The following is a description of a gene set: Metaplastic carcinoma of the breast (MCB) is a poorly understood subtype of breast cancer. It is generally characterized by the coexistence of ductal carcinomatous and transdifferentiated sarcomatous components, but the underlying molecular alterations, possibly related to epithelial-mesenchymal transition (EMT), remain elusive. We performed transcriptional profiling using half-a-genome oligonucleotide microarrays to elucidate genetic profiles of MCBs and their differences to those of ductal carcinoma of breasts (DCBs) using discarded specimens of four MCBs and 34 DCBs. Unsupervised clustering disclosed distinctive expression profiles between MCBs and DCBs. Supervised analysis identified gene signatures discriminating MCBs from DCBs and between MCB subclasses. Notably, many of the discriminator genes were associated with downregulation of epithelial phenotypes and with synthesis, remodeling and adhesion of extracellular matrix, with some of them have known or inferred roles related to EMT. Importantly, several of the discriminator genes were upregulated in a mutant Snail-transfected MCF7 cell known to exhibit features of EMT, thereby indicating a crucial role for EMT in the pathogenesis of MCBs. Finally, the identification of SPARC and vimentin as poor prognostic factors reinforced the role of EMT in cancer progression. These data advance our understanding of MCB and offer clues to the molecular alterations underlying EMT. studied in species Homo sapiens from publication Lien HC, Hsiao YH, Lin YS, Yao YT, Juan HF, Kuo WH, Hung MC, Chang KJ, Hsieh FJ (PMID 17603561) Human Gene Set: LIEN_BREAST_CARCINOMA_METAPLASTIC_VS_DUCTAL_DN Genes down-regulated between two breast carcinoma subtypes: metaplastic (MCB) and ductal (DCB)., and this is the list of marker genes: PLEKHA6, TSTD1, DACH1, ZNF552, ERBB2, ZG16B, IFI44L, AZGP1, PRR5-ARHGAP8, LAMP5, FBXL16 (F-box and leucine rich repeat protein 16), MANEAL, TPD52, AR, DYNLRB2, REEP5, VAV3, SERTAD4, PLAAT3, SCGB1D2, SCGB2A2, MYO5C, TFF3, CREB3L4, TOM1L1, KRT19, EPN3, NHERF1, TMEM125, INPP5J, STK16, EPPK1, COX6C, NAT1, KRT18P64, MMEL1, LRRC17, MUCL1, HCAR1, ABAT, TESMIN, ITGAD, FSIP1, FXYD3, PIP, ADIRF, TMEM25, ZDHHC11, CCDC125, AGR2, SPDEF, ARSD, EPCAM, BIK, FRZB, MB, ACOT4, RTN4RL1, TBC1D9, GRHL2, SCGB2A1, KRT18P55, C11orf52, RSPH1, IL20RA, PRR15L, FOXA1, THRSP, ATOSA, AGR3 (anterior gradient 3, protein disulphide isomerase family member), CDH1, TTC39A, BPIFB1, DNAJC12, MAL2, XBP1, CST6, ZSCAN16, OVOL2 (ovo like zinc finger 2), JCHAIN, PHOSPHO2, ZFP62, ELF4, NPDC1, CA12, SPINT2, PTGER3, SLC25A4, DNALI1, ESR1, TRPS1, CLDN7, GSTM3, EFHD1, P2RY2 (NCBI Gene Id 5029), SCGB1D1, ELL3, AP1M2, PLAAT2, REEP6, CEACAM6, ELAPOR1, RET, CYP4Z1, DHCR24, KLHDC9, MYB, HID1, KRT18, ABCC11, GATA3, NME5, CRB3, KDF1 (keratinocyte differentiation factor 1), ACOX2